The following is a description of a gene set: species: Mus musculus Either of the ends of a spindle, where spindle microtubules are organized; usually contains a microtubule organizing center and accessory molecules, spindle microtubules and astral microtubules. Mouse Gene Set: GOCC_SPINDLE_POLE, and this is the list of marker genes: Kifc1, Tubg1, Topbp1, Abraxas2, Mis12, Nsl1, Aunip, Calm1 (NCBI Gene Id 12313), Tacc3, Numa1, Lzts2, Tubgcp6, Kntc1, Nedd9, Nek6 (NCBI Gene Id 80473), Fam110c, Alpk1, Dync2i1, Katnbl1, Cep89, Kif11, Hsf1, Umod, Cfap53, Rgs14, Aaas, Wdr73, Cdc6, Ckap2, Cenpf, Klhl21, Rmdn2, Fry, Brcc3, Dynlt2b, Rassf10, Misp, Unc119, Ypel5, Ik, Bex6, Kash5, Ctdp1, Tubgcp5, Ctnnb1, Stag2, Diaph3, Zw10, Dctn1, Arhgef7, Dlgap5, Cep128, Stag1, Cep250, Plk3, Haus1, Birc6, Smc6, Irag2, Pkp4, Cep85, Cspp1, Kat5, Smc3, Dctn4, Calm2, Katna1, Golga2, Ccnb1-ps, Cul3, Ccnb1, Bccip, Wdr62, Tubgcp3, Klhl22, Rock2, Cep95, Cdc14b, Ppp2ca (protein phosphatase 2 (formerly 2A), catalytic subunit, alpha isoform), Smc1a, Tubgcp2, Fam110a, Uxt, Gpsm2, Nubp2, Nde1, Topors, Ppp2cb, Psrc1, Tpt1, Spast, Bex4, Nin, Prc1, Katnal2, Nedd1, Spdl1, Tpx2, Sbds, Tmem201, Bod1, Nsfl1c, Mad2l1, Or2a7, Aurkb, Efhc1, Tubgcp4, Aspm, Aurka, Cep104, Ikbkg, Enkd1, Vps4b, Mtcl1, Nek7, Kif20b, Mad1l1, Ckap5 (cytoskeleton associated protein 5), Mapre1, Tbccd1, Cdc20 (NCBI Gene Id 98038), Rmdn3, Eml1, Bnip2, Pmf1, Odf2, Dync1li1, Kif2a, Fam83d, Ralbp1, Lats1, Vps4a (NCBI Gene Id 78220), Sgo1, Ckap2l, Inppl1, Poc1b, Hnrnpu, Ubxn2b, Aurkc, Rae1, Haus8, Fbf1, Plk1, Mapk14, Katnb1, Cep44, Spag5, Nsmce1 (NCBI Gene Id 67711), Ankrd53, Cep19, Map10 (microtubule-associated protein 10), Plk5, Plk2 (polo like kinase 2), Npm1, Cetn1, Fam161a, Emd, Rab11a, Poc1a (NCBI Gene Id 70235), Cdk5rap2, Ttc28, Rmdn1, Rassf1, Git1, Dync1i1, Calm3, Knstrn, Cdc14a, Spout1, Mapkbp1, Nup62, Dsn1, Cep63, Alms1, Tnks, Katnal1 (katanin p60 subunit A-like 1), Cntrl, Nudcd2, Nek2, Kif15, Clasp2, Lats2, Cdc25b, Ddx11